Given this list of marker genes Obscn, Sos2, Arhgef33, Arhgef38, Trio, Fgd3, Vav1, Mcf2l, Arhgef39, Itsn1, Ect2, Vav3, Arhgef19, Sos1, Kalrn, Net1, Abr, Arhgef18, Arhgef11, Akap13, Prex1 (phosphatidylinositol-3,4,5-trisphosphate-dependent Rac exchange factor 1), Mapk8, Rasgrf2, Fgd2, Arhgef3, Arhgef16, Fgd4, Bad, Arhgef10l, Arhgef6, Arhgef37, Arhgef12, Fgd1, Rac1, Arhgef2, Arhgef10 (Rho guanine nucleotide exchange factor 10), Vav2, Plekhg2, Arhgef25, Arhgef17, Arhgef7 (NCBI Gene Id 54126), Gna13, Plekhg5, Mcf2, Arhgef26, Ngef, Arhgef1, Arhgef5, Bcl2l11, Tiam2, Arhgef9, Arhgef15, here is a description of the gene set: Mouse Gene Set: REACTOME_NRAGE_SIGNALS_DEATH_THROUGH_JNK NRAGE signals death through JNK species: Mus musculus